Given this list of marker genes CASP10 (caspase 10), EIF2AK3, FOCAD, IL7R, FAS, ARPC1B, LMNB2, ELF4, XIAP, REL, RNASEH2B, KRAS, ZAP70, FASLG, NRAS, SH2D1A, here is a description of the gene set: Increase in the number or proportion of lymphocytes in the blood. Human Gene Set: HP_INCREASED_TOTAL_LYMPHOCYTE_COUNT Increased total lymphocyte count studied in species Homo sapiens